The following is a description of a gene set: Neighborhood of HMGA2 high mobility group AT-hook 2 in the GCM expression compendium Human Gene Set: GCM_HMGA2 Neighborhood of HMGA2 species: Homo sapiens, and this is the list of marker genes: L1CAM, FABP3, NEFL, PTPRU, MMP19, COX10, CHIC1, CYP2F1, FHL3, CSPG4, CD8B, GPR3, VPS72, IGKV7-3, IKBKE, PRKAG1, AQP7, KRT31, NR2C1, GH2, CCR9, SLC18A1, FEV, PNMT, POP1, RING1, MPP2, CENPI, BDH1, MYBPC2, GCM1, SUPT4H1, POLR1HASP, TAF1, SLC17A2, TRIP13, CSN3, ADORA2A, DPF2 (NCBI Gene Id 5977), SLC14A2, ZNF8, CSN2, IRF5, DRD1, PDE6B, STAT4, VAV1, ITSN1, GHRHR, TMEM94, TEC, NGFR, FUT2, DGCR6, GJA5, TMEM106A, SIRPB1, MVK, SMARCD1 (NCBI Gene Id 6602), CHRM5, COL14A1, PLK1, FCGR2B, MICB, WAS, SSTR3 (somatostatin receptor 3), RABGGTA, NRF1, HMGA2, ERV3-1, PTPN5, ADCYAP1, UROD, AANAT, GRM4, KRT83, NDUFA1, ABCC1, PMS2P11, GSTZ1, MADD, KRT32, ZNF132, IFNA21, SCNN1G, LYST, SERPINB4, ASMT, DRG2, KRT35, AVPR1B, APOC3, CDSN, HTR2C, KCNA6, ODF1, SLC30A3, BNIP1, HTR1E, TUB, BCAT2, EBI3 (Epstein-Barr virus induced 3), TRIM15, FANCC (NCBI Gene Id 2176), RENBP, GRIN2C, ELK4, FCGR2A, MYCL, GABRQ, CHRNE, GCK, CDH5, CCL2, LEP, AGER, CTLA4, PRKCG, CLCN1, ERCC4, SLC2A4, MYH7, PSG7